Given this list of marker genes MICA, LGALS9, TIGIT, CLEC12B, KIR2DL4, IL13, PVR, NECTIN2, FCGR2B, KLRD1, KLRC1, IL7R, PTPRC, IL4, ARRB2, SERPINB4, HLA-G, CR1, CRK, NCKAP1L, GRB2, SERPINB9, PPP3CB, HLA-A, CEACAM1, INPP5D, HLA-B, LILRB1, HLA-E, HLA-F, HAVCR2, CX3CR1, TGFB1, NECTIN4 (nectin cell adhesion molecule 4), here is a description of the gene set: Any process that stops, prevents, or reduces the frequency, rate or extent of cell killing. studied in species Homo sapiens Human Gene Set: GOBP_NEGATIVE_REGULATION_OF_CELL_KILLING